The following is a description of a gene set: Human Gene Set: HP_METHEMOGLOBINEMIA Methemoglobinemia studied in species Homo sapiens Abnormally increased levels of methemoglobin in the blood. In this form of hemoglobin, there is an oxidized ferric iron (Fe +3) rather than the reduced ferrous form (Fe 2+) that is normally found in hemoglobin. Methemoglobin has a reduced affinity for oxygen, resulting in a reduced ability to release oxygen to tissues., and this is the list of marker genes: CYB5A, HBG2, CYB5R3, HBB, HGD, HBA1